The following is a description of a gene set: Genes having at least one occurrence of the motif NWAWNTAGGTCAN in the regions spanning 4 kb centered on their transcription starting sites. This matches the RORA transcription factor binding site V$RORA2_01 (v7.4 TRANSFAC). Human Gene Set: RORA2_01 studied in species Homo sapiens, and this is the list of marker genes: GABRB2, ATP8B2, MYB, IL22, HPCA, ADCYAP1, REST, TTYH1, HOXB2, PCBP4, A1CF, B3GALT2, EGFLAM, PPP2CA, GPRIN3, EIF5A, C1GALT1C1, SIAH3, KCTD15, COX4I2, SP6, CITED1, LNX2, CHRDL1, JMJD1C, TAF5L (NCBI Gene Id 27097), ARF5, TLE4, UBE2L3, UBE2R2, CREB1, GUCY2F (guanylate cyclase 2F, retinal), INPP5A, CIRBP-AS1, LRRC8A, DBP, AP3D1, ZDHHC21, STEAP4, RREB1 (NCBI Gene Id 6239), TRIM29, PIM1, SHH, SLC4A7, EPHA7, C1QTNF4, KMT2C, LONRF3, CNTN6, BMAL1 (NCBI Gene Id 406, basic helix-loop-helix ARNT like 1), CTH, ZNF516-DT, GAS2, FAM193B, NAA40, NPAS2, ANGPT1, HDAC9, MEDAG, NUP210L, TSPEAR, SH3GL2, CSMD3, EPHA3, KRT9, ZFP36L1, CYRIA, TTBK2, RNF144B, IL17F, C1QTNF3, MIEF1, HOMEZ, RYR1, ZNF593, PBXIP1 (NCBI Gene Id 57326), PPP1R3A, APEX2, ESRRB, OGA, NMT2, RALGPS2, TRMT10A (NCBI Gene Id 93587), HSPA4L (NCBI Gene Id 22824), NUBP2, KAT5, LINC00472, ABCA1 (ATP binding cassette subfamily A member 1), ONECUT2, SEMA3A, NLK, CIRBP, MYLK, OPN1SW, CCDC178, KDM3B, PPP1R2C, SPTAN1, ASPH, KLF4, SHKBP1, PITX2, GALT, KHDRBS2, SSX2IP, ABAT, ATP5PD, FBXW4, SYNE1, CHMP2B, TSPAN7, LRRN2, MARCKS, IVNS1ABP, CLOCK, FSBP, DMD, RTL9, MEIS2, PYGM, BEND4, DTNA, GRIA1, SLC18A2, NRL, RCOR1, IL23R, SORBS2, CMTM6 (NCBI Gene Id 55487), CUTA, CAMKK2, PTGR3, TDRP, MPP2, DAB2, CDR2L, LRRC20, MMP14, SLA, PLEKHH2 (NCBI Gene Id 130271), LINC00158 (long intergenic non-protein coding RNA 158), KCNAB3, NECTIN1, GLYR1, TMEFF2, SND1-IT1, ATP1B2, CACNA1A, AP1G2, CDYL, LMO1, ACSL3, TREX2, SOCS2 (suppressor of cytokine signaling 2), TMPRSS3, BABAM1